The following is a description of a gene set: species: Mus musculus The portion of the microtubule cytoskeleton that lies just beneath the plasma membrane. Mouse Gene Set: GOCC_CORTICAL_MICROTUBULE_CYTOSKELETON, and this is the list of marker genes: Pde4dip, Mapre1, Clasp1, Numa1, Clasp2